The following is a description of a gene set: Human Gene Set: MIR508_3P Genes predicted to be targets of miRBase v22 microRNA hsa-miR-508-3p in miRDB v6.0 with MirTarget v4 prediction scores > 80 (high confidence targets). from publication Chen Y, Wang X (PMID 31504780) studied in species Homo sapiens, and this is the list of marker genes: TFAP2B, CRLF3, RAB12, CLOCK, SALL4, PIKFYVE, NUMB, ROR1, SPZ1, LAMTOR3, PTPN9, CERT1, ATL2, DNAJC6, CPNE3, CLASP1, TECTB, ODAM, HTR2C (5-hydroxytryptamine receptor 2C), GLCE, SRPRA, SEPTIN7, TAB3, UBASH3B, TLCD4-RWDD3, DLG2, SORCS1, UGCG, NR2C2, WEE1, RECK, FCHSD2, KCNA4, RBFOX2, RAP2A, HACD3, KIAA1549, NDUFAF6, APOBEC2, ZBTB44, XPR1, CDC14B, NETO1, MAGT1, ACOX1 (acyl-CoA oxidase 1), CAPRIN1, ANXA10, HBP1, CTDSPL2, SDK1, FAM20B (NCBI Gene Id 9917), C2, UPRT, RBMS3, CPNE2, CFL2, MTMR6, RBM27, MINDY2, MBNL1, VAPA, MSTN, MPHOSPH9, AMDHD1, CCL1, ASH1L, LOX, PHYHIPL, KLF4, HMGA2, CECR2, RARS1, ARHGEF12, NFKB1, NSD3 (nuclear receptor binding SET domain protein 3), SLAIN2, STRBP, ADAM28, ARL4C, TRHDE, RNF103, ZBTB18, GXYLT1, CCNA2, HOXA1 (homeobox A1), ADNP, GNRHR, PAK3, RMND1, SCN2A, BICRAL, ZNF397, DCLK1, PROKR2, NCOA1, ZDHHC3, MINPP1, NFIB, RAD23B, CCNYL1 (cyclin Y like 1), MITF, RASSF3, GAB1, NR4A3, GRIA2 (NCBI Gene Id 2891), ELOVL7, IRX2